The following is a description of a gene set: species: Homo sapiens The retention in the endoplasmic reticulum (ER) lumen of soluble resident proteins. Sorting receptors retrieve proteins with ER localization signals, such as KDEL and HDEL sequences or some transmembrane domains, that have escaped to the cis-Golgi network and return them to the ER. Abnormally folded proteins and unassembled subunits are also selectively retained in the ER. Human Gene Set: GOBP_PROTEIN_RETENTION_IN_ER_LUMEN, and this is the list of marker genes: ANKRD13C, OS9, RER1, PDIA2 (NCBI Gene Id 95435), KDELR3, GPAA1, KDELR2, KDELR1